The following is a description of a gene set: Human Gene Set: REACTOME_PHOSPHATE_BOND_HYDROLYSIS_BY_NUDT_PROTEINS Phosphate bond hydrolysis by NUDT proteins species: Homo sapiens, and this is the list of marker genes: NUDT9, NUDT5, NUDT18, ADPRM, NUDT1, NUDT16, NUDT15